The following is a description of a gene set: species: Mus musculus The lipid bilayer surrounding a chromaffin granule, a specialized secretory vesicle found in the cells of adrenal glands and various other organs, which is concerned with the synthesis, storage, metabolism, and secretion of epinephrine and norepinephrine. Mouse Gene Set: GOCC_CHROMAFFIN_GRANULE_MEMBRANE, and this is the list of marker genes: Anxa7, Dnajc5, Atp8a1, Dbh, Syt1, Cyb561, Syt2, Slc17a9, Sri